The following is a description of a gene set: from publication Chen Y, Wang X (PMID 31504780) Genes predicted to be targets of miRBase v22 microRNA hsa-miR-147b-5p in miRDB v6.0 with MirTarget v4 prediction scores > 80 (high confidence targets). studied in species Homo sapiens Human Gene Set: MIR147B_5P, and this is the list of marker genes: R3HCC1L, AKIRIN1, ZNF704, CNRIP1, DIPK2B, KDM3B, CAMKK2, TXNDC15, MAGI2, PCLO, HDLBP, WAC, FAM120A, BCL11A, CMKLR2, FZD6, INO80D, GOSR1, PARPBP, VCF1, IL17RD, APOBEC3B, EBAG9, PTPRM, CLASP2, MBD2 (methyl-CpG binding domain protein 2), PGM3 (phosphoglucomutase 3), DCP1A, DCAF7, PTAR1, G3BP2, CLOCK, CX3CR1, INTS7, IL26, EIF1B, ARAP2, UBE2V1, TXNL1, PDCL, ASTN2 (NCBI Gene Id 23245), RNF8, ARPIN, TENM3, CD164, MESD, SPRED1, CPQ, SUGP2, VGLL3, ZNF407, SLC38A1, SPCS1, PABIR2 (PABIR family member 2), DCBLD2, CHRNB2, PGBD5, GFM1, NAV3, ABCD2, NCK1, SHPRH, TLE1, CS, MAP1B, MAGEA2, THRB, APBB2, ABRA, ADGRD1, PPP2R1B, ACAN (NCBI Gene Id 404712), HAND2, CNIH1, ZNF148, ATXN7, FMNL2, NRP1, COL4A6, NAV2, BMAL1, MFAP3L, GRID2, WDR20, BNC2, TWIST1, POU4F1, PLPPR5, DZIP1, PCYT1B, GMFB (glia maturation factor beta), OTUD4, ARL4C, MED13L, CD40LG, DPF3, CHD9, SVEP1, DLGAP1, SP3 (Sp3 transcription factor), ELAPOR2, KRTAP1-5 (keratin associated protein 1-5), CRACDL, RANBP9, KDM5A, VPS4B, PCSK1, ANAPC1, PCDH11Y, RHOBTB1, LRRTM4, RABL2A, LIN7A, RNF4, TCF7L2, VCPIP1, PMM2, SEC13, ZC3H8, SERP1, CDKN2AIP, PIAS2, INAFM2, PTPRK, ZBBX, ZBTB20, PCDH7, SEC11A, SEMA3A (semaphorin 3A), TLCD4, SSX7, TIGD3, RORA, SYBU (NCBI Gene Id 55638), CACNB4, ARL5A, NEGR1, ZMYND11 (NCBI Gene Id 10771), KAT2B, WASHC4, GRIA2, MAGEA3, LMO1, DLD, DIAPH1, CALHM5, TBL1XR1, RNPC3, CRCP, NPTN, AAK1, KLHL24, CASD1, PRXL2A, TATDN3, NFIB, PLXNA4, APOBEC4, DKK2, FBXL5, NFIA, CHD6, ONECUT2, EMP2, MFAP1, LACTB, CCDC73, TBC1D2B, KMO, RIMKLB, PRKG2, TREML2, NFYC, HTR4, TNFRSF9 (TNF receptor superfamily member 9), MLEC, TBC1D12, TANC2, BRSK2, MTA3, MGMT, BUB3, SH3GLB1, OTUD1, FBXL20, PCDH19, HASPIN, TNKS, MGST2, ZNF789, FBXO22, AGO3, AGPAT5, NHEJ1, MROH2A, MAGEA2B (NCBI Gene Id 266740), NCAM1, PPFIBP1, FXYD6, SERPINB5, KANSL1, FBXL3, SETD9, MAGEA6, RAD51, SCN2A, ADAMTS5, PDE1C, ZC3H12C, ARK2N, CELSR3, TMEM50B (transmembrane protein 50B), SERPIND1, ZBTB34, ZNF160, PRRC2B, SKA1, MOB3B, SLF2, PLCXD3, NFATC2, MEF2C, NEUROD1, RBMS3, ZNF706, PCDH18, AKAP10, SHQ1, INSYN2A, ANGPT1, PHF8, TCF20, STAU2, ARID4B, ADCY6, PHF13, LAMC1, EML4, TBC1D32, NREP, PFN2, FUT9, MCC, EDIL3, TET1, ANXA11, HS2ST1, CWC15, CNGB1, BRAP, TMTC3, NUP58, NAA15, MEIOC, MEX3C (NCBI Gene Id 51320), FMN1, CACYBP, AAR2, BARD1, TOMM22, CEP170, SLC18A2, CAP2, C2orf69, SRSF4, TRANK1, FGG, WDR31, RAB33A, GNG4, SLC30A5, PEDS1-UBE2V1, XPNPEP3, TRIM67, TAF7, SMYD1, FCGR2B, GPR15, RBM22, C1S, ATP6V0D2, PI4K2A, UBE2W, SLTM, EVI2B, RIOK3, TMEM59, MAGEA12, VOPP1, MAP3K1, C9, FAF2, SESN1, ARF1, MYLIP, TNFSF15, NAA20, CRKL, RNF38, RASSF3, NRROS, ALDH1B1, FBXO34, TRIM42, HMGA2, ADNP2, PDE4D, IKZF1, HERC3 (HECT and RLD domain containing E3 ubiquitin protein ligase 3), GABRA1, SNTN, UTRN, VTCN1, SEZ6, ILRUN, PPARA, DDHD1, SYTL4, AFF3, KSR2 (kinase suppressor of ras 2), EMC4, PPP1R3B, PLCB4, AHR